Given this list of marker genes Atp1a2, Pm20d2, Btd, Selenon, Aldh1l1, Gulo, Aldh1l2, Mtrr, Folr1, Mmachc, Mmadhc, Clybl, Ugt1a6a, Gsto2, Plpbp, Clstn3, Vnn3, Vnn1, Pdxk, Cubn, Amn, Dhfr, Pdzd11, Nampt, Slc19a2, Slc52a3, Akr1a1, Nnmt, Slc5a6, Rgn, Mmab, Ero1a, Slc25a19, Nmnat1, Pnpo, Thtpa, Nmnat2, Flad1, Gsto1, Slc19a3, Abcd4, Nmnat3, Akr1b1, Alpl, Mtr, Shmt1 (NCBI Gene Id 97731), Tpk1, Rfk, Slc23a2, Acp3, Gclc, Mthfsl, Mmaa, Slc52a2, Pdxp, Hlcs, Atp1a3, here is a description of the gene set: species: Mus musculus The chemical reactions and pathways involving any of a diverse group of vitamins that are soluble in water. Mouse Gene Set: GOBP_WATER_SOLUBLE_VITAMIN_METABOLIC_PROCESS